The following is a description of a gene set: species: Mus musculus Mouse Gene Set: GOBP_POSITIVE_REGULATION_OF_STRESS_FIBER_ASSEMBLY Any process that activates or increases the frequency, rate or extent of the assembly of a stress fiber, a bundle of microfilaments and other proteins found in fibroblasts., and this is the list of marker genes: S100a10, Rac1, Limk1, Fermt2, Bag4, Rock2, Ppm1e, Arhgef10, Carmil1, Tac1, Rhoc, Tgfb3, Rhoa, Gpr65, Tesk1 (testis specific protein kinase 1), Serpinf2, Pak1, Rgcc, Evl, Tacr1, Nf2, Smad3, Kiss1r, Braf, Ppm1f, Abl1, Limch1, Pdlim4 (PDZ and LIM domain 4), Prkcq, Sdc4, Wnt4, Mtor, Arhgef10l, Myoc, Sorbs3, Nrp1, Arhgef5, Apoa1, Itgb1bp1, Pxn, Rapgef3, Cd47, Lpar1, Tgfbr1, Fhod1, Pfn1, Synpo2l, Pfn2, Arhgef15, Epha1, Ccdc88a, Wnt11, Nox4, Cdc42, Ccn2, Tpm1, Tsc1, Sh3pxd2b